Given this list of marker genes BRIP1, FOXP1, RBL2, FSBP, MDM4, MED13, KATNBL1, TMA16, LOX, DEK, PPM1E, DOCK9, LNPK, RRAGD, DCLK1, GPM6B, LIN7C, FRYL, SGCZ, DPP4, SIX4, PIP4K2A, ILF3, PTPN3, GALM, TMEM131, TIAL1, MAMDC2, EIF3A, GLS, TENT4B, ATF7IP, ZNF780A, PXN, HCAR1, TMEM87A, RLIM, UGCG, SYNJ1, TNKS2, DCBLD2, KRT8, FAF2, USP30, PRKAA1, NCBP3, FRAS1, PPFIA2, KLHL2, APBB2, MSI2, SCLT1, ACBD5, PACS2, AGO4, MTF2, CCDC28A, TTC28, ZNF423, RAB23, PRLR, GPC6, HIPK1, AK4, PHIP, HERPUD1, UBE3C, VCL, CASP8, DTNA, CSNK1G3, NAV1, C18orf63, B3GLCT, GPATCH2L, CHUK, TRPC1 (transient receptor potential cation channel subfamily C member 1), ZNF737, MEX3A, FNTA, NSMCE2, MECP2, GOSR1, POLR1F, RNF38, ALG10B, SLC38A2, CREB1, BDNF, ADARB1, TRIP11, ARHGAP29, SENP7, ATE1, WDR75, CHIC1, PRKAA2, SERINC1, UGGT1, SFT2D1 (SFT2 domain containing 1), GOLM2, NETO1, COL22A1, CENPBD1P, E2F6 (E2F transcription factor 6), BTF3, BNC2, CCDC85C, RPL13A, RAB6D, CELF4, PEX7, CDKN2AIP, CD36, SRSF1, KRTAP19-3, HNF4G, KATNAL1, TMEM65, EGFR, RDX, NUFIP2, KCNV1, CPXCR1, LARP4, ARHGAP42, SP1, TMEM30A, RAB6C, RAB6A, ZNF718, MAPK1IP1L, SORCS1, RC3H1, CORO2A, STON1, RALBP1, MBD5, FREM2, AFF4, PCDH17, ANKRD13A, LRRTM4, CLASP2, BHLHE22, UBE2E3, SMAD5, TET3, TIGAR, ZCCHC3, MAFK, NFATC3, SLC4A7, DNAJC10, C8orf88, RUNX1T1, ORMDL3, CERS3, PGK2, DIXDC1, DCP2, MAGT1, CBFB, MAGEB3, GALNT16, C5orf15, SLBP, N4BP2, IPO11, NDFIP1, HNRNPM, NFIA, TXNDC16, SLITRK2, TLR8, ATP2A2, PLSCR5 (phospholipid scramblase family member 5), PDE3B, ICA1L, PPFIA1, PSIP1, NSUN2, MAU2, AAK1, PREX2, PUM2, GZF1, POLR1B, RB1, ZNF117, AVPR1A, PMP22, VIM, MYLK, KCNH7, ZNF281, CELF2, RTRAF, ONECUT2, MNDA, KCTD9, MOB1B, GOLGA2, ZBED2, CTBS, ZSWIM6, NYAP2, SLC25A15, SIX2, SIAE, STEAP2, BOLL, PHF19, FAT4, LACTB, DCUN1D1, ZNF436, SYT4, UBE2H, B4GALT6, SKP2, DPP8, ABLIM1, HCN4, POLA1, RNPS1, INPP5F, LSM11, HIVEP1, ZNF200 (NCBI Gene Id 7752), ASAP1, FZD3 (NCBI Gene Id 7976), TENT2, USP31, SPRR3, SLC6A6, NDN, FLII, MPPED2, RRAGC, RAB3GAP2, FGF7, SAR1A, CTCF, ARF6, SETD7, TAFAZZIN, KLF9, PID1, CSNK2A1, TFPI, TRA2A, IRF2BP2, BPNT2, TNRC6B, RBPMS, NAA25, ZNF407, ATXN7, RBMS3, FCHO2, SPTLC2, FBXL3, ZNF148, LIFR, NR2C2, SETD2, SPIN3, PPP1R1C, SPPL2A, LEF1, RAB9B, SLC12A2, PCYOX1L (prenylcysteine oxidase 1 like), ELAVL1, PER2, PPP2R5A, SAMD5, BCLAF3, BBX, GPATCH2, JMY, ZNF280D, ADAM10, RPAIN, SUN1, CCDC126, BMP3, KANSL2, STXBP5L, CAVIN1, YAP1, DGKE, RPGRIP1L, EXOC5, TMEM182, ST6GAL2, CASP2, QKI, AFTPH (aftiphilin), KLHL28, NFATC1, TMTC1, PPARGC1B (PPARG coactivator 1 beta), ESRRG, CSTF2, MAP1B, ATP2B1 (ATPase plasma membrane Ca2+ transporting 1), RETREG1, LRCH2, PYURF, CDK5R1, PARP11, LEPR, PLD5, GABRG3, SAMD9L, SAMD4A, RCAN1, GNB4, SAMD8, PRR32, STX6, NAA50, TLK2, HNRNPR, RBPJ, MCF2L, USP25, TXLNG, LATS2, CLK2, SCNN1G, CADM2, MARVELD1, PCM1, KRCC1, ABL2, CACUL1, NAP1L5, COL19A1, NPTN, PLAA, PDZD2 (NCBI Gene Id 23037), TAF1, GUCY1A2, LCA5, ZNF99, BMAL1, ASZ1, PCNX1, UBLCP1, PIGW, MICAL3, ABHD13, DOK6, NOM1, NPTX1, RAMAC, STK26, NEGR1, SDC1, ZMAT3, RNF217, PRKG2, CDH11, C5orf46, LPGAT1, FNDC3A, EMC1, NR1D2, CACNA2D1, BRI3, BPNT1, TAOK1, RIMBP2 (NCBI Gene Id 23504), ANXA2R, RBM47, UBE2W, KDM6A, KCNB1, TOX3, NEBL, HIPK3, KPNA1, DYRK1A, CCDC47, IER5, PRKAB2, ARHGAP6, PURA, CADPS, OSBPL8, ZHX3, UBE2V1, SRSF3, EIF2S2, RAP2C, C6orf47, ZSCAN2, ZDHHC2, MXD1, LHFPL2, SESN1, CPEB2, RIMKLB, FMR1, RAB21, CCDC18, PEG10, LARGE1, UBQLN1, ZFP91, CDK19, UBN2, G6PC2, PAX5, CARNMT1, NUCKS1, LUC7L2, BRWD3, KIAA1671, MFAP3L, HEPHL1, STRN (striatin), MBLAC2, SULT1B1, RIC1, NOL4, DNAJC11, HERC3, BOD1L2, SYT10 (NCBI Gene Id 341359), CIAO2B, UFSP2, PHF6, PRPF40A, CASP8AP2, BAG4, EIF4E3, FAAH2, CNOT6L, PAPOLG, STRADB, TLCD4, VASN, MAP7D2, PIK3C2A, TMEM106B, SIPA1L2, GPRC5B, PTBP2, BLTP1, DMXL1, UHRF2, ERO1B, PTPA, ESR1, SLC13A1, RNF138, ARPP19, CHRNA7 (cholinergic receptor nicotinic alpha 7 subunit), EEPD1, FGD4, PCDH19, ATXN3, SNX18, GLCCI1, NPFFR2, CDK12, DCX, RIMS1, TXNL1, GOLGA3 (NCBI Gene Id 2802), HDAC9, KALRN, CREBRF, CDK13, SGMS1, SNX13, DCAF12, ZBTB20, MINK1, CCDC71L, SLC16A1, PRKAR1A, COL3A1, CTTN, BTBD3, NF1, ARL6IP1, GMFB, NCOA3, NME7, CALCRL, RAB18, GABRA1, SPAG9, VPS13C, SLC2A13, SEC61A1, PLAGL2, AHR, ZNF518B, PABIR2, EFNB1, FSD2, VGLL3, RNGTT, EHHADH, KLHL20 (NCBI Gene Id 27252), CEP97, RRM2B, PDE10A, PRKACB, IGF1R (insulin like growth factor 1 receptor), KRT5, NSD1, NUP37, CYP2U1, MIB1, RAB4A, RAPGEF6, LANCL1, ATP4B, CTNNA1, MAP2K1, ANKRD28, IGSF3, CXCL16, ZW10, GOLPH3, PCDH10 (protocadherin 10), ADAMTS5, PRSS12, TUB, SLITRK4, CDCA7, MAP3K20, MACROH2A2, RSKR, RC3H2, BLTP3B, PTPRG, ZHX1, FOXJ3, DIP2A, CEP57L1 (centrosomal protein 57 like 1), ZRANB2, PPP1R9A, TMEM161B, ZKSCAN4, TDRD10, ANTXR1, ARHGAP26, STARD9, AMOT, KLHL7, BLCAP, WDR33, RAD54B, ADCY9, EIF5A2, RFX3, NR3C1, CCDC82, FRMD6, SNTB2, ISOC1, H2AJ (NCBI Gene Id 83739), CSMD3, TMEM248, CLRN1, SLC35B4, FAM76B, RAB11FIP2, BAMBI, CARF, DIAPH3, SOWAHA (NCBI Gene Id 134548), TMEM26, HAUS2, ATXN1, TMTC2, ILRUN, CCSAP, TBPL1, BICRAL, SRSF11, KDM5A, ADAR, MAP3K2, TOR1AIP2, ADAM12, TAF12, CALM2, MAST4, GPR63, PLPP3, TRAF6, FLRT2, LDLRAD3, ZC3H11A, MYT1L, RMND5A, ARK2N, RFTN2, CHD7, PLEKHA8, DOCK4, FBXO42, SOCS5, SRGAP2B, ORC5, ZDHHC21, EED, STK40, NLGN4X, HNRNPC, LYAR, ITCH, CEP57, BIRC6, ANTXR2, PPM1L, ZNRF3, LMO3, CTCFL, REXO2, NME1, ARMT1, PCDHB7, DIAPH1, PHF14, RAB12, TSC1, NPY1R, GCA, KMT5A, CNOT6, KMT2E, NAPB, FLYWCH2, PCDH11X, TET2, EMILIN3, RNF169, SLC36A4, THOC7, BAHD1, SPCS2, MME, BAZ2A, JOSD1, JAM3, CDH2 (cadherin 2), AK9, THSD7B, PPP2R5E (protein phosphatase 2 regulatory subunit B'epsilon), IPPK, RSBN1, ARHGEF9, NXPE3, UBE2G1, AP3M1, PCSK1, XKR6, SV2C, G0S2, HABP4, SPINK5, LEMD3, KPNA6, UBR7, NCOA1, ETS1, DPY19L3, LCOR, GSE1, BACH2, ZNF618, ZBTB18, ZFTA, RD3L, PEDS1-UBE2V1, ARHGAP5, TSPYL5, PRP4K, SKA3, LGR5, KIF17, KDM7A, ZNF138, GTF2A1, SYTL4, LRCH1, RORA, MCM6, TES, PAX3, PIGA, CYRIB, GSPT1, MDM1, PDE1A, ZNF107, ADI1, PTPRT, FAM199X, TENM1, CLOCK, SMPD3, TMEM101, ZHX2, WAPL, RING1 (ring finger protein 1), ZNF813, ARAF, NIPSNAP3B, ADIPOR1, TBL1XR1, ATP1B3, CTTNBP2NL, GK5, RGCC, SPIC, VSTM2A, CTNND1, EEA1, HMGXB4, QSER1, HOXC8, PAPPA, ABCA5, HCFC2, SEPTIN11, ZMYND8, N4BP2L1, REPS2, ATF2, SFXN1, FRY, SH3BGRL, GADL1, CREB5, here is a description of the gene set: Human Gene Set: MIR548E_5P studied in species Homo sapiens Genes predicted to be targets of miRBase v22 microRNA hsa-miR-548e-5p in miRDB v6.0 with MirTarget v4 prediction scores > 80 (high confidence targets). from publication Chen Y, Wang X (PMID 31504780)